The following is a description of a gene set: Fibrin monomers rapidly and spontaneously associate into large multimers, which in turn elongate into protofibrils that later aggregate to form fibers, creating a three-dimensional network. This structural organization is essential for the mechanical properties of the clot. The fibrin network is further stabilized by Ca2+ -dependent cross-linking of fibers, which is mediated by the thrombin-activated factor XIII (FXIIIa). Adhesion of integrin αIIbβ3, a platelet surface receptor, to the fibrin network contributes to platelet aggregation and stabilizes the forming clot (Litvinov RI et al., 2016; Höök P et al., 2017). The process of fibrin clot formation has been reviewed in detail (Medved L & Weisel JW 2009; Weisel JW & Litvinov RI 2017; Pieters M& Wolberg AS 2019; Butera D & Hogg PJ 2020; Murano G 2024). part of: Coagulation pathway species: Homo sapiens Reactome Pathway: Fibrin formation, and this is the list of marker genes: F2, FGA, ITGA2B, FGB, SERPINA5, SERPINE2, PROC, ITGB3, SERPIND1, SERPINC1, F13B, FGG, F13A1